Given this list of marker genes EYA1, ZDHHC5, CLCN1, PTHLH, ZSCAN20, RABL6, HS6ST2, MBIP, PDP1, ZNF638, RHOBTB2, PRDM8, PREX2, NFIL3, BSN, LRRTM3, SPRY4, MACO1, MPP2, SARNP, POGZ, KLF9, ABHD8, PMEPA1, TAGLN3, AK3, CHIC2, MCTP1, BCL6, TOB1, NTN5, CIART, IRF2BP1, CAPS, ATF3, LINC00472, WDR47, ARHGAP44, LAMP5, TFEB, SYT6, TNFSF13, OSBPL6, FAM76A, SERPINE2, NPTX2, PER2, AKTIP, EPB41, USP2, ERGIC1, SH2B3, CALM2, TSC22D1, ORMDL2, GRHL1, FGF14, CSNK1E, CRTAC1, PDXP, HRH3 (NCBI Gene Id 11255), GNPNAT1, PALS2, ZNF711, HIVEP3, RPS6KA6, ZFYVE9, ADNP, CADM1, WDR81, RBMS2, RCC2, RASL10B, JMJD1C (NCBI Gene Id 9323), KCNC1 (potassium voltage-gated channel subfamily C member 1), CLASP1, ANO1, NAA60, NRSN1, IMPDH1, STK35, UBR5, CD40LG, TSPAN7, MKNK2, TUBB2B, RAB24 (RAB24, member RAS oncogene family), TBX6, PRNP (NCBI Gene Id 96713), FNBP1, NDST3, PRKG1, RPS6KA3 (ribosomal protein S6 kinase A3), MECP2, ERF, OTP, IL34, SYT11, SREBF2, EP300, G6PC1, CLSTN1, MIR22HG, IL1RAPL1, MBNL2, ZBTB14, CFAP68, CREB5, MID1IP1, AHNAK, IP6K2, COL15A1, RGS6, MED12L, EPN2, TSC22D3, UNC5C, AMY2A, ARID1B, ANKRD40, WNT8B, LARGE1, SAMTOR, GABARAPL2, CDK2AP2, AP1S2, DGKI, TREX1, WEE1, NR1D1, PALS1, IKZF2, SEC14L3, CNTF, SUMO1, CDC42, FKRP, ADRB2, HERPUD1, FBXW7, C1orf122, TNS2, NEGR1, YWHAG, DENND4A, GPM6A, SULF1, CRIM1, NEUROD6, CELF2 (CUGBP Elav-like family member 2), MAP2K6, RNF145, TMUB2, ETV5, CALM1, DAGLA, DMD, TSPYL2, NREP, PRELID1, YRDC, TRIM8, PCSK2, ALB, FBXO3, LMO4, GABRR2, ID4, PELI2, MREG, LINC00671, ZNF687, RPL23 (ribosomal protein L23), ELAVL4, STARD13, IRAK1, BCL11A, ARRDC3, EEF2, ETV4, ZBTB21, INPP4A (inositol polyphosphate-4-phosphatase type I A), MAP2K3, here is a description of the gene set: Human Gene Set: CREBP1_01 studied in species Homo sapiens Genes having at least one occurrence of the motif TTACGTAA in the regions spanning 4 kb centered on their transcription starting sites. This matches the ATF2 transcription factor binding site V$CREBP1_01 (v7.4 TRANSFAC).